The following is a description of a gene set: studied in species Mus musculus The chemical reactions and pathways resulting in the formation of nucleotide-sugars, any nucleotide-carbohydrate in which the distal phosphoric residue of a nucleoside 5'-diphosphate is in glycosidic linkage with a monosaccharide or monosaccharide derivative. Mouse Gene Set: GOBP_NUCLEOTIDE_SUGAR_BIOSYNTHETIC_PROCESS, and this is the list of marker genes: Gfpt2, Gne, Gfus, Uap1, Mpi, Slc2a1 (solute carrier family 2 (facilitated glucose transporter), member 1), Slc35a1, Ugp2, Fpgt, Nans, Gmppa, Pgm3, Pmm1 (phosphomannomutase 1), Gnpda2, Hk1, Amdhd2, Uxs1, Fuom, Cmas, Gnpda1, Uap1l1, Gmppb, Pmm2, Gnpnat1 (glucosamine-phosphate N-acetyltransferase 1), Gfpt1, Gmds (NCBI Gene Id 97904), Slc35c1, Fcsk, Ugdh, Nanp (NCBI Gene Id 67311)